Given this list of marker genes MT-ND6, MT-TK (NCBI Gene Id 4566), DEPDC5, MT-ATP6, MT-TV, JRK, MT-ND2, CNTNAP2, NRXN1, SLC2A1, MT-TL1, MECP2, ARL13B, BTD, FBP1, GABRA1, MT-ND5, CABP4, GABRB3, CAMK2B, CHRNB2, TCF4, CIZ1, GABBR2, MT-ND4, KCNT1, CDKL5, CASK, CHRNA2, MT-ND1, CPLANE1, HLCS, CRH, TLK2, SYT1, CACNA1H, GABRG2, CHRNA4, MT-ND3, UQCRFS1, MT-TW, here is a description of the gene set: Hyperventilation Hyperventilation refers to an increased pulmonary ventilation rate that is faster than necessary for the exchange of gases. Hyperventilation can result from increased frequency of breathing, an increased tidal volume, or both, and leads to an excess intake of oxygen and the blowing off of carbon dioxide. species: Homo sapiens Human Gene Set: HP_HYPERVENTILATION